The following is a description of a gene set: C57Bl/6 wild-type and STAT6 KO mice were used to study PPARg and IL-4 signaling. Bone marrow of 3 mice per group was isolated and differentiated to macrophages with M-CSF (20 ng/ml). 20 ng/ml IL-4 was used to induce alternative macrophage activation and 1 uM Rosiglitazone (RSG) was used to activate PPARg. From each mouse 4 samples were generated: 1. M-CSF, 2. M-CSF+RSG, 3. IL-4 and 4. IL-4+RSG. All compounds were added throughout the whole differentiation process, and frech media was added every other day. Control cells were treated with vehicle (DMSO:ethanol). After 10 days, RNA was isolated and gene expression profiles were analyzed using Mouse Genome 430 2.0 microarrays from Affymetrix. from publication Szanto A, Balint BL, Nagy ZS, Barta E, Dezso B, Pap A, Szeles L, Poliska S, Oros M, Evans RM, Barak Y, Schwabe J, Nagy L (PMID 21093321) Genes up-regulated in bone marrow-derived macrophages: wildtype versus STAT6 knockout. studied in species Homo sapiens Human Gene Set: GSE25088_WT_VS_STAT6_KO_MACROPHAGE_UP, and this is the list of marker genes: RASA3, PLGRKT, HMGN2, CS, KCNN1, ATXN7L3B, RANBP10, ODC1, SFT2D3, ARL6IP4, RPL10A, CTDP1, CHP1, SNHG32, PPP2R5A, ENSG00000253557, OXCT1, TRMT5, LMNB2, PEBP1, GALC, RPL4, SLC22A23, BACH2, ANP32A, ALPK2, COX4I1, FAHD2A, DYRK4, MRPL45, TOR3A, IVD, SUV39H1, ARID1B, RASSF5, TNXB, CLEC4G, CBLB, BNIP1, RPS12, UBE2E1 (NCBI Gene Id 94682), ZNF844, AKAP13, PANK1, CAMK1G, FAM234A, MED12, PI15, PARP12, ASPM, HIGD2A, RPL41, AFG1L, GAS5, LITAF (lipopolysaccharide induced TNF factor), PIN1P1, SFXN4, PAK1, TERF2, RELB, TRMT1, PRORSD1P, MYL5, PTPN18, STH, EIF2S3, UBXN1 (UBX domain protein 1), XAGE3, LRPPRC, IFRD1, ERLEC1, TMCO4, SFMBT1, GGTA1, ZNF496, SND1, ZNF618, MEPCE, ERGIC2, ZSCAN32, CLEC16A, TMEM62, STEAP1B, PFKM, PTCD3, ABHD10, SH3BP5-AS1, RPS2, COX7A2L, ZMAT1, NSA2, PHB2, F10 (coagulation factor X), RXRB, MANBA, UBE2E2, GBP4, KMT2D, MRAS, MT1M (NCBI Gene Id 4499), KCNH2, MICAL1, GPHN, RMI2, SDS, C1QC, AGA, NFIA (nuclear factor I A), SDSL, SRPRB, ERGIC3, PCP4L1, HMG20B, LINC01592, OPA1, APOL6, FARP2, HMG20A, AURKB, SPECC1L, PRKAB1, EYA4, SOX7, HSPD1, TMEM192, APH1A (aph-1 homolog A, gamma-secretase subunit), EPRS1, STARD7, FECH, PLCZ1, TOE1, MGLL, CLCN5, RAMP1, CCDC66, PPM1J, GTPBP1, MALT1, PITHD1, MYO15B, RNF182, SSX2IP, XPO4, LMO4 (LIM domain only 4), SPC25, SLC39A3, RXYLT1, LIN54, RPLP0, TMEM216, BCL2L13, RPN2 (ribophorin II), CDK5RAP3, ATRN, RPS10, GSAP, MND1, NFS1 (NFS1 cysteine desulfurase), DDB2, SNHG11, PSMG2, ICA1, ACY1, RACK1, GRN, NBEAL2, HEXIM2, TOMM70, MBOAT2, SEPTIN11 (NCBI Gene Id 55752), SLC25A41, MIR663AHG, CSMD1, TLE4, RAD54L2, TIMM9, TRAF7, LINC03025, ZDHHC18, JOSD1, MCM6, GOLM2, PLEKHG4 (pleckstrin homology and RhoGEF domain containing G4), RPS13, IFI44, GOLM1, CREBL2, PHACTR3, SRPRA, ST7-AS1, RPS23, SEC11A, FAF1, TESC, RUBCN, LDB1